The following is a description of a gene set: studied in species Mus musculus Any process in which an organism modulates the frequency, rate or extent to which it enters into the host organism, where the two organisms are in a symbiotic interaction. Mouse Gene Set: GOBP_MODULATION_BY_SYMBIONT_OF_ENTRY_INTO_HOST, and this is the list of marker genes: Tmprss2, Itgav, Trim30d, Trim12a, Exoc2, Exoc7, Trim11, Trim25, Trim30a, Trim62, Lgals1, Cd4, Tmprss4, Smpd1 (NCBI Gene Id 20597), Furin, P4hb, Cd74, Trim12c, Trim5, Ch25h, Trim30c, Trim30b, Hmgb1, Trim38, Hs3st5, Fuca2, Cav1, Nectin2, Bsg